Given this list of marker genes Epb41l2, Lrrtm1, Epb41l5, Lrrtm4, Grm1, Nlgn2, Cask, Dlgap4, Nrxn2, Epb41l3 (NCBI Gene Id 56528), Nrxn3, Nlgn3, Nlgn4l, Dlg3, Shank1, Shank3, Nlgn1 (neuroligin 1), Dlgap1, Epb41, Homer1, Dlg2, Dlgap2, Lrrtm3, Lrrtm2, Homer3, Nrxn1, Dlgap3, Grm5, Sorbs2, Dlg4, Homer2, here is a description of the gene set: species: Mus musculus Mouse Gene Set: REACTOME_NEUREXINS_AND_NEUROLIGINS Neurexins and neuroligins